The following is a description of a gene set: An abnormality of calcium concentration in the urine. Abnormality of urine calcium concentration Human Gene Set: HP_ABNORMALITY_OF_URINE_CALCIUM_CONCENTRATION studied in species Homo sapiens, and this is the list of marker genes: CLCNKA, CLIP2, CDKN1C, OCRL, HNF1B (HNF1 homeobox B), GTF2I, FAM20A, BSND, EIF4H, DNAJC30, NDUFAF6, BAZ1B, GCM2, GNA11, CASR, PIGT, CDC73, NCF1 (NCBI Gene Id 653844), FXYD2, CFTR, CLDN16 (NCBI Gene Id 107986170), EHHADH, AP2S1, SLC12A3, TMEM270, ADCY10, SLC12A1, FKBP6 (FKBP prolyl isomerase family member 6 (inactive)), GRHPR, CLDN19, LIMK1, VPS37D, MLXIPL, BUD23, PIK3C2A, STX1A, CLDN10, CYP27B1 (NCBI Gene Id 5135), SLC22A12, ELN, RFC2, ATP6V0A4, FGF23, SLC2A2, CDKN2C, BTNL2, ATP7B, TNFRSF11B, GTF2IRD1, HLA-DRB1, CDKN1A, PTH1R, FCGR2A, AMMECR1, ALPL, GATM, INSR, CYP24A1, KCNJ5, TBL2, SLC2A9, CDKN2B, GTF2IRD2, CDKN1B, CLCN5, PHEX, CLCNKB, MEN1, METTL27, TGFB1, SLC34A3, MAGED2, KCNJ10, SLC34A1, KCNJ1